The following is a description of a gene set: Mouse Gene Set: GOBP_REGULATION_OF_LYSOSOMAL_LUMEN_PH studied in species Mus musculus Any process that modulates the pH of the lysosomal lumen, measured by the concentration of the hydrogen ion., and this is the list of marker genes: Snapin, Vps33a, Oca2, Tmem199, Tmem175, Lamp2, Tmem9, Lrrk2, Ccdc115, Grn, Tmem106b, Cln5, Tmem165 (NCBI Gene Id 21982), Atp6v0c, Creg1, Ppt1, Cln6, Atp6ap2, Slc45a2, Lamp1, Cln3, Spns1, Tasl